The following is a description of a gene set: Any process that results in a change in state or activity of a cell or an organism (in terms of movement, secretion, enzyme production, gene expression, etc.) as a result of an organophosphorus stimulus. Organophosphorus is a compound containing phosphorus bound to an organic molecule; several organophosphorus compounds are used as insecticides, and they are highly toxic cholinesterase inhibitors. species: Mus musculus Mouse Gene Set: GOBP_RESPONSE_TO_ORGANOPHOSPHORUS, and this is the list of marker genes: Aldh3a1, Pnpt1, Kdm1a, Fbp1, Oxt, Ptgs2, Aanat, Duox2, Pik3cg, Rapgef3, Trpv1, Cited1, Tyms, Lncbate10, Pik3r1, Ndufs4, P2rx6, Igfbp5, Ins1, Duox1, Inpp5k, Birc2, Thbd, Gpd1, Itpr3, Akap6, Asph, Pde3a, Kcnq1, Ryr1, Lpar1, Ass1, Nt5e, Pkd2, Fosl1, Itpr1, Agxt, Errfi1, Akap7, Aqp8, Itpr2, Hmgcs2, Kcne1, Rapgef1, Slc8a3, Srebf1, P2rx3, Panx1, Dgkq, Slc6a3, Kcnj8, Hsp90b1, Mat2a, Pfkfb1, Slc8a1, Pdxp, Stat1, Cyp1b1, Ren1, Gata6, P2rx4, Ahr, Pck1, Pklr, P2ry6, P2rx5, Rplp0, Ccl2, Inhbb, Pax4, Casp1, Ssh1, Fos, Cdo1, P2rx1 (NCBI Gene Id 18568), Dntt, Star, Kcnj11, Pde2a, Braf (Braf transforming gene), Penk, P2rx2, Abcc9, Aqp1, Plcg2, Fosb (NCBI Gene Id 14282), Pde4d, Cftr, P2ry12, Slc26a6, Adipoq, Wnt10b, P2rx7, Bsg, Crem, Tlr7, Hcn4, Pygm, Crhbp, Bckdhb, Akap9, Areg, Tyr, Hmga1, Cdk2, Eef2k, Vgf, Slc26a3, Rap1b, Ezr, Fdx1 (NCBI Gene Id 14148), Rap1a, Crtc3, Cyp27b1, Crls1, Crtc1, Trpc3, Cnga3, Npr2, Sell, Col1a1, Cps1, Gata1, Dmtn, Hcn2, Il1b, Trpm4, Mmp19, Cib2, Hcn1 (hyperpolarization activated cyclic nucleotide gated potassium channel 1), Zfp36l1, Rela, Ptk2b, Stc1, Ryr3, Rapgef2, Top2b, Ptafr, Rfc3, Crtc2, Slc6a4, Carm1, Sdc1, Per1